Given this list of marker genes Nlrp5, Cdkn2c, Rbl2, Pkp4, Kash5, Atp2b4, Llgl2, Inip, Arpp19, Egfr, Kif18b, Dctn1, Pkia, Septin3, Ecrg4, Ripor2, Axin2, Ncapd3, Hyal1, Mtcl2, Ccna1, Fancm, Iffo1, Tacc3, Cntrob, Cyp26b1, Wee2, Orc4, Actl6b, Nek10, Sirt7, Ppp6c, Anp32b, Klhl13, Calm2, Cep55, Tas2r102, Nfe2l1, Cep120, Cdk7, Rad51d, Meiob, Ssx2ip, Rrm2b, Ube2l3, Mcmbp, Fes, Itgb1bp2, Recql5, Exoc7, Usp19, Srpk1, Anapc5, Dmc1, Pebp1, E2f1, App, Rb1, Poldip2, Rrp8, Pum1 (pumilio RNA-binding family member 1), Cenpq, Prpf4b, Klf4, Fen1, Sox15, M1ap, Anxa11 (annexin A11), Stk11, Csf1r, Topbp1, Mapre2, Wapl, Golga2, Klf11, Fbxo5, Pard6b, Msx2, Pds5a, Chmp5, Ofd1, Msx1, Babam1, Pclaf, Ncaph (non-SMC condensin I complex, subunit H), Spast, Skp2, Cdk5rap2, Tti1, Txlng, Ccne2, Cdkn1c, Hmga2, Exoc5, Zw10, Rae1, Trim36, Atr, Ccnd3, Npm1, Smc4, Tiprl, Kif20b, Nup43, Plk3, Abraxas2, Dstn, Mbd4, Cdc20, Map3k11, Ubr2, Dmrt1, Reep3, Exoc2, Ranbp1, Smarca2, Btn2a2, Ddb1, Serpine1, Hormad1, Filip1l, Sfpq, Tmem67, Cdc7, Ppp2r5d, Spc25, Meikin, Cdc14a, Smarcb1, Birc5, Iho1, Rab11fip4, Stk38, Arl2 (ADP-ribosylation factor-like 2), Haus3, Clasp1, Nudt16, Hnrnpu, Ppp2r3d, Wac, Ccnd1, Neurog1, Fgfr1, Fbxo4, Syce1, Id2, Cdc5lrt1, Exoc4, E2f7, Sptbn1 (NCBI Gene Id 268394), Mir124a-1, Crocc, Entr1, Ovol1, Tjp3, Psmg2, Fbxo7, Ncapd2, Ppp2ca (protein phosphatase 2 (formerly 2A), catalytic subunit, alpha isoform), Piwil2, Cetn1, Ccar2, Pdgfb, Ccng1, Ube2e2, Upf1, Spata22, Rangrf, Tpd52l1, Prkce, Ckap2, Chd3, Tppp, Hinfp, Cxcr5, Sun1, Eme2, Tubb1, Tpx2, Nfib, Tesmin, Kif3b, Gper1, Ctnnb1, Fbxl15, Cdk2, Nasp, Mepce, Hus1b, Rhoa, Cdkn2b, Fbxw11, Blm, Top3b, Bag6, Aurka, Cdc16, Nek11, Cdc5lrt7, Met, Ooep, Cdk18, Plk1, Haus7, Poc5, Washc5, Abraxas1, Mtcl1, Brme1, Smarcad1, Sde2, Kif2a, Rad54l, Cdc5l, Sh3glb1 (NCBI Gene Id 99782), Septin7, Kif20a, Cacul1, Spry2, Mir124a-3, Stk35, Pinx1, Spry1, Znhit1, Mme, Cdca5, Nsfl1c, Orc1, Susd2, Mir26a-2, Parp9, Cdk5r1, Usp29, Bmp7, Gas1, Deup1, Nek1, Stag1, Flna, Ago4, Ush1c, Tex19.2, Pik3r4, Inhba, Gadd45a, Cdk3, Eml4, Rrm1, Il1a, Foxj3, Rassf1, Kifc1, Phip, Bcl7c, Zwint, Nat10, Exoc8, Cep85, Edn3, Dscc1, Haus4, Apc, Camk2d, Pkn2, Atf2, Cenph, Hus1, Spin1, Nme6 (NME/NM23 nucleoside diphosphate kinase 6), Ctdsp2, Tubg1, Pibf1 (progesterone immunomodulatory binding factor 1), Plk4 (polo like kinase 4), Htt, Top3a, Mcmdc2, Cdc42, Fgf10, Ndc80, Zwilch, Trrap, Ik, Cdca8, Fbxo43, Mapre3, Nde1, Brcc3dc, Mbtps2, Insm2, Rpl10l, Pdpn, Trex1, Cep250, Cep63, Mcph1, Fignl1, Pabir1, Drd3, Cav2, Pbx1, Rnf4, Cep126, Ezh2, Cep295nl, Mad2l1, Ppp3ca, Prpf40a, Ccnh, Rbl1, Usp50, Uvrag, Anapc2, Phf10, Ccno, Gtf2b, Asz1, Cenpt, Oip5, Psma8 (NCBI Gene Id 73677), Cdkn1b, Macroh2a1, Rmi1, Pcid2, Zc3h12d, Taok2, Kat2b, Kat14, Cenps, Epgn, Abcb1b, Ehmt2, Inppl1 (inositol polyphosphate phosphatase-like 1), Ncapg, Myb, Kat5, Cenpn, Myo19, Septin14 (septin 14), Smc3, Brox, Calr, Ctdspl, Sin3a, Itgb3bp, Zfp207, Tlk1, Lmna, Smc2, Septin6, Usp47, Nppc, Ercc4, Chek2, Smarcd3, Rad17, Ccnjl, Rnaseh2b, Mitd1, Snx33, Prap1, Brd4, Hormad2, Map10, Dync1h1, Cetn2, Wee1, Cdc5lrt6, Smarcd2, Taok3, AY074887, Cenpa, Atm, Pkp3, Igf1, C2cd3, Bin1, Chmp7, Cul4a, Spag5, Fanca, Mastl, Wnt10b, Sgo2a, Mad2l1bp, Ube2u, Usp8, Taf2, Rad21, Ctdp1, Ska1 (NCBI Gene Id 66468), Ptprv, Ints3, Rcc2 (regulator of chromosome condensation 2), Xrcc2, Actb, Myo16, Psme2, Eml1, Aunip, Limk2, Dyrk3, Ciao1, Camk2a, Eif4g3, Rspo1, Ist1, Cdc45, Shoc1, Lef1, Tle6, Stxbp4, Stambp, Acvr1b, Cep135, Ccnc, Esr1 (NCBI Gene Id 13982), Brca2, Foxj2, Ccnb1-ps, Snhg15 (small nucleolar RNA host gene 15), Gen1, Fzr1, Rock2, Tubgcp3, Ncor1, Ins1, Usp17le, Dot1l, Zpr1, Zfp830, Cdc25a, Spart, Setdb2, Zfyve19, Rad50 (NCBI Gene Id 19360), E2f5, Mcm5, Gpr132, Terb1, Pola1, Ythdf2, Drd2, Ctcf, Mrgprb1, Dmrtc2, Actr3, Hecw2 (NCBI Gene Id 329152), Syce3, Mlh3, Nsmce2, Rps6 (ribosomal protein S6), Naa10, Ccdc61, Ankfn1, Pds5b, Smarca5, Bub3, Rec8, Tfap4, Crnn, Tipin, Cdk2ap2, Hsf2bp, Ccnb3, Slc25a5, Septin2, Aif1, Trim71, Kmt2e, Ubxn2b, Ccnb1 (NCBI Gene Id 268697), Cdk10, Prox1, Rock1 (NCBI Gene Id 68785), Fem1b, Mdm1, Ambra1, Gnb1l, Pcm1, Kif18a, Eif2ak4, Sbds, Mei4, Gpsm2, Tk1, Arhgap33os, Rhob, Ints13, Pdcd6ip, Hspa2, Fbxl7, Tom1l1, Ticrr, Mtbp, Fbxw7, Ddx4, Ptpn6, Chtf8, Fsd1, Cpsf3, Tacc2, Csnk2a2, Meiosin, Gpsm1 (G-protein signalling modulator 1 (AGS3-like, C. elegans)), Cenpo, Rad1 (NCBI Gene Id 19355), Ccdc69, Tpr, Ccdc57, Pttg1, Tert, Pcnt, Exoc6b, Misp, Osm (oncostatin M), Sugt1, Lats2, Nfia, Sfrp1, Pin1, Id4, Rint1, Dgkz, Arl8b, Rfwd3, Smarce1, Bcl7b, Ddx11, Usp22, Setmar, Zcwpw1, Ccnl2, Hoxa13, Bex6, Tdrkh, Tubgcp2, Ube2srt, Sox9, Naa60, Azin1, Psme1, Cntln, Pnma5, Msh5 (NCBI Gene Id 279936), Ecd, Chek1, Tcf3, Myh10, Tbx2, Larp7, Stmn1, Tex19.1, Tdrd12, Cdca2, Dnm2, Arf6, Brsk2, BC034090, Shcbp1l, Zbtb17, Mis12, Aspm, Spire2, Tacc1, Kif23, Ahctf1, Mms19, Trim75, Cdc27, Rptor, Haus8, Bid, Terb2, Dbx2, Six3, Psme3, Rgcc, Kif2c, Bcl2, Spc24, Cdkn2d, Fam83d (NCBI Gene Id 99445), Kcna5, Sass6, Septin10, Prmt2, Kif4, Atrx, Cdc5lrt5 (NCBI Gene Id 668198), Mapk15, Unc119, Pafah1b1, Mzt1, Ska2, Uimc1, Parp3, Rpl24 (NCBI Gene Id 68193), Il1b, Nusap1, Gsk3b, Map1s, Cenatac, Spo11, Ercc6, Cdc14b, Gpr15lg, Stard9, Mad1l1, Cc2d1a, Fbxw5, Psmc3ip, Ccni, Mnat1, Phgdh, Seh1l, Plcg2, Top6bl, Champ1, Cdk1, Anapc4, Bard1 (NCBI Gene Id 12021), Morc2b, Top1, Usp51, Tbce, Ppp1r10, Rrs1, Crebbp, Anapc15, Mdc1, Apbb1, Slc16a1, Mre11a, Rad21l, Anapc11, Rad51ap1, Dctn3, Gnai1, Ccnq, Tom1l2, Btbd18, Mau2, Aaas, Igf2, Ppp2r5b, Dact1, Lsm10, Haus6, Tnks, Luzp1, Capn3, Mybl1, Lats1, Cdk4, Ccdc42 (coiled-coil domain containing 42), Plk5, Tnf, Brcc3, Dlgap5, Sac3d1, Cdk11b, Aicda, Ccdc15, Apbb3, Rttn, Xpo1, Cd28, Ankle1, Aven, Foxm1, Bex4, Pdxp, E2f8, Eml3, Ilk (NCBI Gene Id 16202), Jade1, Cdc5lrt10, Tex15, Nfatc1, Usp37, Chmp1a, Dynlt1b, Mki67, Dab2ip, Appl2, Cep131, Ercc3, Bnip2, Suv39h2 (suppressor of variegation 3-9 2), Xrcc3, Prickle1, Cenpl, Bcas2, Kif11, Senp6, Mov10l1, Sirt2, Chtf18, Becn1, Sycp2, Creb3l1, Pim2, Plec, Septin8, Tdrd9, Nes, Dbf4 (DBF4 zinc finger), Ufl1, Ttl (tubulin tyrosine ligase), Gipc1, Cdk5rap3 (CDK5 regulatory subunit associated protein 3), Smarcd1, Abcb1a, Top2a, Bub1b, Nabp2, Snx18, Pkhd1, Taf10, Cdkn2a, Tcim, H2-M3, Pmf1, Spdl1, Ccng2, Gata6, Reep4, Ier3, Rad51b, Etaa1, Phf8, Cenpu, Med1, Son, Psmd13, Dpf3, Rps6kb1, Fam107a, Obsl1, Ing2, Hjurp, Rgs14, Vcp, Sycp1, Lsm11, Pax6, Npm2, Igf1r, Ensa, Ercc2, Btc, Sycp3, Chmp1b, Usp44, Men1, Rps27l, Naa50, Ing4, Itgb1, Stk33, Nipbl, Zfp365, Mcm4, Pkmyt1, Smc6, Racgap1, Exoc6, Wnt16 (NCBI Gene Id 93735, wingless-type MMTV integration site family, member 16), Slf2, Smpd3 (NCBI Gene Id 80691), Egf (epidermal growth factor), Tfdp1, Septin4, Syce2, Nbn, Ctc1, Mael, Ube2i, Usp9x, 4933427D14Rik, Anapc7, Ddr2, Brip1, Svil, Ccn2, Cdk16, Pdik1l, Pstpip1, Rnf112, Fancd2 (NCBI Gene Id 78247), Rhno1, Lzts2, Haus1, Ctdsp1, Strada, Eif4e, Fhl1, Gpnmb, Cenpf, Trip13, Zfp36l1, Rad18, Daxx, Ubb, Atxn10, Hacd1, Plk2, Rmi2, Cep68, Ddx3x, Mcm3, Ckap5, Mir124a-2, Nek6, Insm1, Hspa8, Rad51c, Sstr5, Bbs4, Fmn2 (formin 2), Cenpx, Ankk1, Ect2, Mettl13, Rny1, Iqgap2, Ank3, 4930447C04Rik, Dtl, Zmpste24, Acvr1, Efhc1, Cep295, Ppm1d, Npat, Mtmr4, Stil, Calm1, Tex12, Eme1, Zfp503, Ndp, E4f1, Chordc1, Rbbp8, Myh9, Senp2, Ndel1, Septin9, Kctd19, E2f6, Map9, Cep72, Rbm14, Trappc12, Gjc2, Zbed3, Nuf2, Fgfr3, Bccip, Ccl12, Ccnf, Aurkc, Msh4, Mnd1, Wnk1, Phb2, Gins3, Lig1, Ccnb1ip1, Stx2, Sirt1, Septin5, Zfp36l2, E2f3, Cenpj, Tpra1, Nup62, Tgfa, Hsf1, Hfm1 (HFM1, ATP-dependent DNA helicase homolog), Brdt, Setd2 (SET domain containing 2), Ccny, Spice1, Baz1b, Cdc6, Rnf212b, Ncapg2, Ppp2r1a, Ilkap, Rhoc, Rpl17, Slc25a31, Mapre1, Tmsb4x, Smarca4, Cul4b, Pum2, Pard6g, Trp53, Ankrd31, Stag3 (STAG3 cohesin complex component), Incenp, Mei1, Ska3, Cep152, Rtkn, Chmp1b2, Rdx, Numa1, Nfix, Poc1b, Nek2, Sgo2b, Pkd2, Kat2a, Mos, Slf1 (NCBI Gene Id 72573), Lcmt1, Rny3, Pbrm1, Dpf2, H2ax, Spdya, Rcc1, Mblac1, Clock, Haus5, Klhl18, Kif14, Uxt, Rab35, Cltc, Eif4ebp1, Romo1, Mrnip, Mir664, Ubd, Mcm2, Stag2, Nanos2, Atad5, Prpf19, Akap8, Myh14 (myosin, heavy polypeptide 14), Wiz, Cdc73, Cenpm, Klhdc8b, Dctn2, Cyp27b1, Nop53, Wnt4, Syce1l, Smarcc2, Ppp1r12a, Exoc3, Ppp2r2d, Wdr76, Actr2, Kif22, Pik3c3, Tuba1a, Vps4a (vacuolar protein sorting 4A), Cdt1, Bcl7a, Cep44, Ino80, Slfn1, Katnb1, Gja1, Smarcc1, Usp33 (ubiquitin specific peptidase 33), Cacnb4, Ccna2, Exoc1, Cit, Kntc1, Mlh1, Plscr1, Hepacam2, Akt1, Chmp6, Firrm, Drg1, Gpr3, Cdk17, Kif13a, Hdac8, Kif2b, Smc1a, Plcb1, Camk2b, Pard6a, Banf1, Arl8a, Tubgcp5, Ppp2r1b, Cdkn1a, Cenpk (centromere protein K), Mcm6, Clasp2, Ezr, Enkd1, Rbm46, Ercc1, Ccnl1, Mus81, Rpa2, Bcl2l1, Bora, Sdccag8, Git1, Meioc, Washc1, Rrm2, Cdc5lrt9, Xpc, Cdk5 (cyclin dependent kinase 5), Pde4dip, Snx9, Syde1, Smc5, Ccsap, Cul3, Trim37, Cks2 (NCBI Gene Id 66197), Aurkb, Mlf1, Ppp1r35, Ccdc8 (coiled-coil domain containing 8), Ccnb2, Mbtps1, Mark4, Syf2, Stra8, Hspa1a, Iqgap1, Cfl1, Alms1, Spire1, Dctn6, Pagr1a, Mcm7, Zfp655, Psrc1, Ncaph2, Lsm14a, Apbb2 (NCBI Gene Id 69484), Foxn3, Rps3, Mapk14, Usp26, Cdc25b, Rnf212, Dicer1, Anapc15-ps, Bmp4, Wdr6, Anapc1, Haspin, Plpp2, Mdm2, Atf6b, Ppp2r2a, Wnt5a, Trim39, Stox1, Cry1, Plrg1, Dusp1, Kiz, Grb14, D7Ertd443e (DNA segment, Chr 7, ERATO Doi 443, expressed), Septin1, Atrip, Dsn1, Ankrd53, Prdm9, Zfp541, Chfr, Wdr90, Paf1, Mybbp1a, Kif15, Eif4g1, Cdc5lrt4, Cep76, Vps4b, Poc1a, Cdk6, Ube2b, Chmp3, Chmp2a (charged multivesicular body protein 2A), Esco1, Pias1, Gins1, Myc, Slx4, E2f4, Csnk2a1, Ccnj, Nsl1, Miip, Alkbh4, Cdc23, Ttk, Rad9a, Fam110a (family with sequence similarity 110, member A), Clspn, Cdk14, Ints7, Arhgef10, Tmod3, Tbx1, Appl1, Mta3, Dna2, Sapcd2, Khdc3, Tubg2, Fgf8, 1700028K03Rik, Ptpn11, Prkdc, Cables1, L3mbtl1, Hsf5, Bmyc, Kcnh5, D1Pas1, Ciao2b, Donson, Pde3a, Ccp110, Cenpw, Arl3, Pten, Top2b, Rps6ka2, Tubb5, Fgfr2, Rab11fip3, Gigyf2, Sh2b1, Tubgcp6, Birc6, Lin37, Babam2, Cspp1, Tm4sf5, Nae1, Fbxo30, Cdc25c, Phf13, Marf1, Klhl9, Cul9, Tbx20, Sgo1, Siah1a, Foxo4, Prkcq, Anln, Lsm14b, Cenpp, Iqgap3, Kdm8, Tubgcp4 (NCBI Gene Id 74395), Cdk15, Bend2, Kcnn4, Uhrf1, Ccne1, Dpf1, Cenpc1, Prc1, Dach1, Usp28, Arid1a, Csnk1d, Ywhah, Actl6a, Snd1, Cirbp, Camk2g, Ccnd2, Zfy2, BC005624, Bcl2l11, Brca1, Ntmt1, Apex1, Nuggc, Pole, Rtel1, Ythdc2, Rxfp3, Nudc, Nabp1, Cep192, Dnmt3l, Cul7, Ins2, Ereg, Lif, Majin, Mir26b, Gmnn, Esco2, Riok2 (NCBI Gene Id 73706), Jtb, Fbxo31, Terf1, Nin, Catsperz, Atf5, Ube2a, Calm3, Wdr62, Dis3l2, Ube2s, Usp16, Tas1r2, Tlk2, Klhl21, Sox2, Adamts1, Llgl1, Ciao2a, Crlf3, Mapk8, Ankrd17, Cdc5lrt8, Kif3a, Dync1li1, Rpl23, Afg2b, Msh2, Lyn, Nsun2, Recql4, Npr2, Arf1 (NCBI Gene Id 11840), Hdac3, Kpnb1, Arid2, Rad51, Zscan21, Ube2c, Cks1b, Cpeb1, Trp63, Chmp4c, Tex14, Mir26a-1, Mybl2, Dcaf13, Tex11, Gem, Adam17, Tcf19, Rhou, Tas2r124, Rtf2, Akap8l, Gli1, Rad9b, Rab11a, Ndc1, Wasl, Ptprc, Map4, Dtx3l, Pdgfrb, Arhgef2, Zfyve26, Taok1, Chmp2b, Ednra, Cenpi, Dlg1, Kifc5b, Brd7, Smc1b, Mn1, Cntd1, Mis18a, Wrn, Wrap73, Pkd1, Paxip1, Trp53bp1, Cenpv, Dcun1d3, Ccdc66, Espl1, Pogz, Septin12, Dazl, Pla2r1, Knstrn, Brsk1, Ran, Pcna, Tgfb1, Cetn4, Ppp2r5c, Tas2r121, Klhl22, Edn1, Lmnb1, Chmp4b, Hspa1b, Nup37, Timeless (timeless circadian clock 1), Cyp1a1 (NCBI Gene Id 13076), Septin11, Ptpa, Nubp1, Rprd1b, Ankle2, Anxa1, Haus2, Ppp1r7, Sphk1, Lrp5, Knl1 (NCBI Gene Id 76464), Map3k20, Insr, Cenpe, Bub1, Eps8, Diaph3, Rec114, Rad54b, Cep97, Kank2, here is a description of the gene set: Mouse Gene Set: GOBP_CELL_CYCLE_PROCESS The cellular process that ensures successive accurate and complete genome replication and chromosome segregation. studied in species Mus musculus